Given this list of marker genes DIAPH1, LAMTOR3, CD59, UBE2H, CFAP141, PARP8, SHISA6, RASA2, C17orf100, ZFAND3, ERF, ARVCF, STAU2, CCN2, CSNK1A1, SETBP1, CENPQ, SCN7A, AMOTL2, PPP2CB, PTPRC, PDGFA, ZNF704, FGF14, GSKIP, SYT1, LAMTOR1, UBE4B, PAN3, TMEM248, UBXN2B, CADM1, BPTF, CENPB, CDK16, RPGRIP1L, MAFB, TCEAL1, AKAP13, CLIC5, CD8B, IRX4, ROCK2, GALNT18, ADAM19, EIF4B, SEC24C, PATL1, PHF3, SATB2, HIPK1, HPSE2, NEO1, ATP2B4, DAGLA, ATRX, TBC1D4 (TBC1 domain family member 4), CYRIA, SOHLH1, SMYD5, TLE3, RPE65, ATP2B2, CACNB1, POLI, INPP4A, HOXC5, NTRK3, CDR2L, KCNK9, PRDM11, DDX3Y, ACTR3, TPM3, JRK, here is a description of the gene set: Genes predicted to be targets of miRBase v22 microRNA hsa-miR-4690-5p in miRDB v6.0 with MirTarget v4 prediction scores > 80 (high confidence targets). from publication Chen Y, Wang X (PMID 31504780) species: Homo sapiens Human Gene Set: MIR4690_5P